The following is a description of a gene set: Human Gene Set: GOBP_NEGATIVE_REGULATION_OF_LAMELLIPODIUM_ASSEMBLY studied in species Homo sapiens Any process that decreases the rate, frequency or extent of the formation of a lamellipodium, a thin sheetlike extension of the surface of a migrating cell., and this is the list of marker genes: HRG, ABI3, CFL1, PLXNB3, MIR196A1, SLIT2, MIR214